Given this list of marker genes MAP3K3, USP47, NKX2-2, PRKCE, CTNNA2, MDGA2, AGFG1, MOB1B, ATP1B1, BCL11A, SREK1, SCN3A, PRDM1, CDKN1C, MS4A13, TRAF7, HOXC11, PBRM1, CNOT7, LEF1, BMP4, OSM, BARHL1, TOGARAM1, SEMA6D, STAG2, FBXW7, CPEB4, GDF6, DGKH, EMILIN2, SLTM, DLG3, PPP1CB, MARK3, NELL2, PAX6, TIAL1, ADGRL3, SECISBP2L, RAPH1, WDR26, FMN2, LHX8 (NCBI Gene Id 431707), RAB22A, PTPN2, SLC4A7, ANO4, DNAJC13, NEUROD1 (NCBI Gene Id 7853), SLC24A4, RSBN1, CCDC6, AGAP1, MAB21L1, KMT5B, RBM24, TBL1XR1, MIP, CNIH1, PCDH19, BRD4, RBMS3, EEF1AKMT2, PJA2, LONRF1, DAB2IP, IQSEC2, OLFML2B, MTDH, BACH2, MAF, RGS17, NEXMIF, SORBS2, UNKL, ANKRD12, PCDH9, EIF4G2, XPO4, MEAF6, SORCS1, DHX30, SGMS1 (NCBI Gene Id 93538), BICD2 (BICD cargo adaptor 2), ESRRG, EDARADD, AGAP4, MED13L (NCBI Gene Id 23389), KCND2, GGNBP2, PARP16, ZER1 (zyg-11 related cell cycle regulator), LPGAT1, MEIS1, CHD9, MFN1, NCOA1, AKIRIN1, MBNL1, SP3, KCNJ3, REV3L, ZFX, DAZL, EP300, THRA, ZIC1, NDFIP1 (NCBI Gene Id 80762), NR4A3, UNC79, TSPYL4, RPS6KB1, STAT5B, HECW1, PCF11, RAB21, FAM43A, DYRK1A, ATP2B2, GRIK2, GTF2H1, DLL1, MDM2, TET1, TP63, RUNX1, BAGE2, here is a description of the gene set: Human Gene Set: GTGCAAA_MIR507 species: Homo sapiens Genes having at least one occurence of the motif GTGCAAA in their 3' untranslated region. The motif represents putative target (that is, seed match) of human mature miRNA hsa-miR-507 (v7.1 miRBase).